Given this list of marker genes LAMB1, DCHS1, EML1, TUBG1, COL4A2, CRPPA, TUBB, KIF2A, TUBGCP2, CEP85L, PAFAH1B1, FAT4, here is a description of the gene set: A form of heterotopia were the mislocalized gray matter is located deep within the white matter. Subcortical heterotopia studied in species Homo sapiens Human Gene Set: HP_SUBCORTICAL_HETEROTOPIA